Given this list of marker genes Dyrk2, Pomc, Phkb, Gabarapl1, Phkg1, Gys2, Ptges3, Atg2a, Ppp1ca, Enpp1, Akt1, Gaa, C1qtnf2, Il6st, Lepr, Prkag2, Wipi2, Pask, Pygb, Nr1d1, Ppp1r3e, Ppp1r3g, Esrrb, Slc37a4, Irs1, Inpp5k, Pgf, Npc1, Ppp1r3d, Khk, Gsk3b, Gnmt, Igf1, Ugp2, Adcy10, Pygm, Ppp1r3b, Phkg2, G6pc1 (glucose-6-phosphatase catalytic subunit 1), Gck, Gys1, Pfkm, Acadm, Ppp1cc (protein phosphatase 1 catalytic subunit gamma), Gfpt1, Mtor, Wipi1, Insr, Phka1, Phlda2, Stk40, Akt2, Epm2aip1, Nhlrc1, Adrb1, Gcgr, Igf2, Pcdh12, Ppp1r3f, Atg2b, Ins2, Gbe1, Pth, Prkag3, Gyg1, Ppp1r1a, Agl, Atg3, Epm2a, Atg12, Stbd1, Gsk3a, Hmgb1, Pgm1, Comt, Ppp1r2, Ppp1r3c, Phka2, Rubcnl, Ppp1cb, Pgm2, Irs2, Wdr45b, Ppp1r3a, 1810024B03Rik, Adra1b, Tcf7l2, Blvra, Ins1, Mgam, Grb10, Rb1cc1, Per2, Pygl, Sorbs1, Wdr45, here is a description of the gene set: species: Mus musculus The chemical reactions and pathways involving glucans, polysaccharides consisting only of glucose residues. Mouse Gene Set: GOBP_GLUCAN_METABOLIC_PROCESS